The following is a description of a gene set: species: Mus musculus Binding to a monosaccharide. Monosaccharides are the simplest carbohydrates; they are polyhydroxy aldehydes HnC(=O)H or polyhydroxy ketones HnC(=O)mH with three or more carbon atoms. They form the constitutional repeating units of oligo- and polysaccharides. Mouse Gene Set: GOMF_MONOSACCHARIDE_BINDING, and this is the list of marker genes: Fuom, P4ha1, Fbp1, Aldoa, Plod3, Gck, Siglecf, P3h3, Cd209f, Sftpd, Gyg1, Slc2a5 (NCBI Gene Id 56485), Lgals1, Man2b1, Gnpnat1, G6pd2, Cln5, Pklr, Cd209c, Plod2, Clec4a4, Pygl, Gys1, Igf2r, Clec4f, Hkdc1, Pfkl, P3h1, Colec10, P4ha2, Gys2 (glycogen synthase 2), Hk3, Asgr1, P3h2, Gpi1 (NCBI Gene Id 676974), Clec4a2, Cd209d, Hk2, Lman2l, Ogfod2, Mgl2, Manba, Selp, Hk1, Plod1, Cd209b, Pgls (6-phosphogluconolactonase), G6pdx, P4ha3, Bsg, Clec4g, Rpe, Alpk1, Clec4d, Dpm1, Egln2 (egl-9 family hypoxia-inducible factor 2), Lgals3, Clec4a3, P4htm, Lman2, Egln3, Ogfod1, Eng, Aldob, Clec10a, Slc2a8 (solute carrier family 2, (facilitated glucose transporter), member 8), Lman1l, Phyh, Lman1, Pam, Colec11, Egln1, Acr, Ogfod3, Mbl2, Taldo1, Mrc1, Slc2a3, Pfkm, Tkt, Siglece, Mbl1, Clec4n, Asgr2, Cd209e, Ugp2, Dbh, Rpia, Cd209a, Galk1, Clec4a1